The following is a description of a gene set: studied in species Mus musculus Mouse Gene Set: WP_ONECARBON_METABOLISM_AND_RELATED_PATHWAYS One-carbon metabolism and related pathways, and this is the list of marker genes: Ahcyl1, Chkb, Gsr, Etnk1, Pcyt2, Gpx7, Sardh, Chka, Gpx6 (NCBI Gene Id 75512), Gpx3, Gpx4, Chpt1 (choline phosphotransferase 1), Csad, Pcyt1b, Agxt2, Bcat1, Gclm, Dmgdh, Gpx5, Pcyt1a, Tyms, Sod3, Mtr, Dnmt3a, Cept1, Dnm1, Shmt2, Bcat2, Bhmt, Sod2, Shmt1, Gpx1, Dhfr, Mat2a, Pld1, Gad2, Cbs, Sod1, Cth, Mat1a, Etnk2, Gnmt, Baat, Chdh, Bhmt2, Gclc, Pemt (NCBI Gene Id 18618), Gpx2, Cdo1, Gad1 (NCBI Gene Id 228010), Gss, Mthfr